The following is a description of a gene set: Human Gene Set: GOBP_PURINE_NUCLEOTIDE_CATABOLIC_PROCESS species: Homo sapiens The chemical reactions and pathways resulting in the breakdown of a purine nucleotide, a compound consisting of nucleoside (a purine base linked to a deoxyribose or ribose sugar) esterified with a phosphate group at either the 3' or 5'-hydroxyl group of the sugar., and this is the list of marker genes: PFKP, PRKAA1, APP (NCBI Gene Id 351), PGK1, NUPR1, GPI, NUDT9, SLC4A4 (NCBI Gene Id 8716), PDE4B (NCBI Gene Id 5142), ARNT, RPTOR, NUDT13, PDE4C, OGDHL, PDE7A, PDE8A, PGAM4, PPP2CA, SARM1, BCL2L13, PFKFB1, HINT1, NUDT11, TRIM63, PDE8B, PDE9A, PDE4D, PGAM2, PDE10A, PGK2, NT5C1B, GAPDHS, ZBTB7A (NCBI Gene Id 56976), ADA, PRKAG1 (NCBI Gene Id 5571), IER3, BPGM, KAT2B, HIF1A, PFKL, INSR (NCBI Gene Id 3643), GPD1, TIGAR, OGDH, MLXIPL, NT5C2, PDE7B, PDE2A, NUDT10, TREX1, EIF6, PRTFDC1, PRKAG3, NUDT18, NT5C, NUDT15, COL6A1, SRC, NUDT12, NCOR1, PRXL2C, UCP2, HK3 (NCBI Gene Id 3101), ENTPD1, PRKAG2, ARL2, IFNG, GCK, FKRP, DNPH1, ITPA, PSEN1, PGM1, SLC4A1, STAT3, FOXK2, FBP1, SIRT6, GAPDH (NCBI Gene Id 2597), ENO2, PFKFB2, MTOR, ALDOB, GIT1, PFKM, HK2, AMPD3, UCHL1, NUDT17, OGT, NUDT4 (nudix hydrolase 4), LIPA, MLST8, HDAC4, ENO4, ALDOC (aldolase, fructose-bisphosphate C), ACTN3, NUDT4B, IGF1, FOXK1, DHTKD1, XDH, ENO3 (enolase 3), ZBTB20, EP300, ENO1, NUDT3 (nudix hydrolase 3), SLC2A6, GALK1, PKLR, HPRT1, PGAM1, NT5E, PDE1A, NT5C1A, MFSD8, LDHA, GDA (guanine deaminase), HKDC1, TPI1, ADPGK, PFKFB3, PDE5A, NUDT16, HTR2A, ALDOA, PRKAA2, PRKACA, P2RX7, FLCN, PNP, SAMHD1, MTCH2, JMJD8, PKM, PDE4A, DDIT4, INS, PPARA, HK1, CBFA2T3, ENTPD4